Given this list of marker genes PDIA6, SRPRA, SEC61G, TXNDC15, SLC35B1, RRBP1, PPIB, HERPUD1, SEC63, CRELD2, OSTC, PDIA3, SLC3A2, CCPG1, PDIA4, KDELR2, LMAN1, LAPTM4A, TMED9, ERLEC1, ATF4, HSP90B1, SDF2L1, DNAJB9, CDK2AP2, HYOU1, CKAP4, MLEC, DNAJC3, SELENOK, SRPRB, DNAJB11, ARF4, RPN2, HM13, ISG20, MANF, FKBP11, FKBP2, HSPA5, PRDX4, CALR, MYDGF, SEL1L, PLPP5, HSP90B2P, LMAN2, SELENOS, here is a description of the gene set: from publication Gavish A, Tyler M, Greenwald AC, Hoefflin R, Simkin D, Tschernichovsky R, Galili Darnell N, Somech E, Barbolin C, Antman T, Kovarsky D, Barrett T, Gonzalez Castro LN, Halder D, Chanoch-Myers R, Laffy J, Mints M, Wider A, Tal R, Spitzer A, Hara T, Raitses-Gurevich M, Stossel C, Golan T, Tirosh A, Suvà ML, Puram SV, Tirosh I (PMID 37258682) In this study, an extensive analysis was conducted to define meta-programs (MPs) capturing intra-tumor heterogeneity across a spectrum of tumor types. The approach utilized non-negative matrix factorization (NMF) to analyze each cell type separately within individual tumor samples. This involved the analysis of malignant cells, macrophages, fibroblasts, endothelial cells, epithelial cells, T-cells, and B-cells. NMF was executed with varying parameter values (K=4, 5, 6, 7, 8, 9), thereby generating 39 programs for each cell type per sample. Each NMF program was summarized by the top genes based on NMF coefficients.\nRobust MPs were then delineated for each cell type using a set of stringent criteria, including recurrence within the same tumor, similarity to programs in other tumors, and non-redundancy within a tumor. Subsequently, these robust NMF programs were clustered (per cell type) based on Jaccard similarity, leading to the identification of MPs associated with each cell type.\nTo enhance the quality of the MPs, a refinement steps were undertaken, involving the removal of MPs suspected of reflecting low-quality data (with an overrepresentation of ribosomal proteins or mitochondrial-encoded genes), single-study inclusion, or similarity to miss-annotated cell types. Human Gene Set: GAVISH_3CA_MALIGNANT_METAPROGRAM_9_UNFOLDED_PROTEIN_RESPONSE Genes upregulated in subsets of cells of a given type within various tumors species: Homo sapiens